Given this list of marker genes AP1M1, GOLPH3L, AP1G1, LDLRAP1, AP2A2, AP1G2, AP1S2, AP2A1, STON1, GOLPH3, STON2, DAB2, AP2M1, HIP1, HIP1R, AP1S1, AP4E1 (adaptor related protein complex 4 subunit epsilon 1), AP2S1, AP2B1, AP1S3, AP1M2, here is a description of the gene set: Human Gene Set: GOMF_CARGO_ADAPTOR_ACTIVITY Binding directly to the structural scaffolding elements of a vesicle coat (such as clathrin or COPII), and bridging the membrane, cargo receptor, and membrane deformation machinery. studied in species Homo sapiens